The following is a description of a gene set: Mouse Gene Set: GOBP_PEPTIDE_ANTIGEN_ASSEMBLY_WITH_MHC_CLASS_II_PROTEIN_COMPLEX The binding of a peptide to the antigen binding groove of an MHC class II protein complex. studied in species Mus musculus, and this is the list of marker genes: H2-Eb1, H2-Eb2, H2-DMa, H2-Aa, H2-Ab1, H2-DMb1, H2-DMb2, H2-Ob, H2-Ea, B2m, H2-Oa